The following is a description of a gene set: Human Gene Set: REACTOME_DEGRADATION_OF_AXIN species: Homo sapiens Degradation of AXIN, and this is the list of marker genes: TNKS2, PSMB3, SEM1, AXIN2, PSMD2, PSMA5, PSMD7, PSMA1, PSMB7, PSMB6, PSMD14, PSMD1, RNF146, PSMB4, PSMD12, PSMB2, AXIN1, PSMC6, PSMC1, PSMA4, PSMD13, PSMA3, ADRM1, PSMA7, UBB, PSMB1, PSMA6, PSMB5, PSMD8, UBC, PSMC3, TNKS (tankyrase), PSMC2, PSMD6, SMURF2 (SMAD specific E3 ubiquitin protein ligase 2), PSMD11, PSMA2, UBA52, PSMD3, RPS27A, PSMC4, PSMC5